The following is a description of a gene set: Genes predicted to be targets of miRBase v22 microRNA mmu_miR_12202_5p in miRDB v6.0 with MirTarget v4 prediction scores > 80 (high confidence targets). studied in species Mus musculus Mouse Gene Set: MIR_12202_5P from publication Chen Y, Wang X (PMID 31504780), and this is the list of marker genes: Sik3, Tbpl1, Pramel25, Fchsd2, Slco4c1, Inpp5j, Clmp (CXADR-like membrane protein), Arl8b, Rad21, Mlxip, Hkdc1, Ccdc184, Syncrip, Zfp229 (zinc finger protein 229), Mxi1, Pi4kb, Thoc3, Dhx35, Selenoi, Pramel29, Ier3, Chmp1b2, Ubxn2b, Tmem255a, Upb1, Dsel, Ppp1r12c (protein phosphatase 1, regulatory subunit 12C), Zc3h12a, Ube2k, Foxa3, Luc7l2, Pgm3, Gpc4, Guca2b